The following is a description of a gene set: Human Gene Set: HP_INTESTINAL_ATRESIA species: Homo sapiens Intestinal atresia An abnormal closure, or atresia of the tubular structure of the intestine., and this is the list of marker genes: ZNF699, PPP1R12A (protein phosphatase 1 regulatory subunit 12A), ITGB4, PI4KA, CAMK2A, FANCF, FOXH1 (forkhead box H1), CFAP45, SHH, NDUFB11, WBP11, FOXF1, CHRM3, FGF8, DISP1, MYCN, FBN2, RTTN, FGFR1, AP1S1, DYRK1A, PORCN, HCCS, SPINK5, TRIP13, SUFU, DLL1, ITGA6 (NCBI Gene Id 3655), FREM2, CRIPTO (cripto, EGF-CFC family member), BUB1, CENPF, SIX3, SALL1, BUB1B (BUB1 mitotic checkpoint serine/threonine kinase B), ZIC3, GMPPB, SIN3A, CHD7 (NCBI Gene Id 780907), RFX6, RERE, ZIC2, CLMP, RFWD3, PIGN, GLI2, TCTN3, NODAL, GAS1, MIR17HG, FLI1, FANCB, CEP57, TTC7A, COX7B, MYH11, CDON, STAG2, SLC25A12, RAD51C, KDM3B, SON, PTCH1, BUB3, DIS3L2, TGIF1, FANCI